Given this list of marker genes CPLANE1, CEP55, SALL1, SIX1, POMT2, RMND1, SMO, ZNF148, MYCN, KIAA0586, PAX2, PIGT, CASK, TTC8, CDKL5, TBX1, PBX1, MBTPS2, NPHP3, FKRP, PIEZO2, SCN1B, CPT2, BICC1, ITGA8, GNAO1, GATA3, PIGQ, IFT140, SEC61A1, DYNC2H1, TRIM8, INTS1, ITGB4, ITGA6, SLC25A22, SCN2A, KMT2D, FIBP, HNF1B, GRB10, PIGN, DMXL2, AMMECR1, GRM7, CSPP1, SDCCAG8, LARGE1, SON, POMT1, GREB1L, EYA1, JAG1, NEUROD2, GLI3, SLC32A1, FKTN, ZNF699, TP63, COQ7, PNKP, TBX18, PIGP, ARX, PLVAP, WNT4, USP9X, GRIN1, PLEC, SIX5, SIK1, KDM6A, KCNA1, BNC2, here is a description of the gene set: species: Homo sapiens The presence of developmental dysplasia of the kidney. Renal dysplasia Human Gene Set: HP_RENAL_DYSPLASIA